The following is a description of a gene set: Human Gene Set: MIR6764_5P Genes predicted to be targets of miRBase v22 microRNA hsa-miR-6764-5p in miRDB v6.0 with MirTarget v4 prediction scores > 80 (high confidence targets). species: Homo sapiens from publication Chen Y, Wang X (PMID 31504780), and this is the list of marker genes: TSPAN17, MLEC, SUSD2, SZT2, SYS1, TNFSF8, KCNJ12, VPS37D, SET, FAM107A, PRRT4, IFITM10, ZFYVE27, ADRA2B, TEAD3, SNPH, PRAG1, SNX33, FBXL18, MIGA2, WNT3A (NCBI Gene Id 89780), PFKFB3, RNF121, BTD, KCNC1, PGPEP1 (NCBI Gene Id 83542), TMEM229B, KCNC2, MIDEAS, ARMC5, SPRING1, RUNX3, TAGLN2, SLC18A1, PBXIP1, NFIC, RAB1B, UCP3, GUF1, VASH1 (vasohibin 1), ATF7IP2, TMEM217, PKP1, LARP1, EFR3B, STC1, ADCY6, GIGYF1, GRM6, PREX2, RBFA, OAZ2, MAVS, SLC8A2, IGFN1, NFASC, CACNG2, TRARG1, VWA3A (von Willebrand factor A domain containing 3A), ECE1, PAQR4, CHTF8, SLC7A8, TRIM67, NPLOC4, ZNF471, TEF, PPP2R5D, ADAMTS4, PCDHGA12, PBX2, APRG1, KREMEN1, CNOT9, PRR30 (NCBI Gene Id 339779), C12orf75, HEYL, DEAF1, TMEM184B, ITPK1, PTPN7, MMP24, TFE3, ZNF629, CWC27, PDE1B, PTPA, TMEM250, NEURL1B, OVOL1, LSS, CACFD1, RPH3A, SIAH2, ACTB (actin beta), NHSL1, ANKRD52, OLFML2A, ZBTB4, SRF, TPBGL, LIN28A, PNMA8B, DPYSL3, LIAT1, BAP1, KIF13A, SPRR2F, MDM4, PTPN6, ZNF474 (NCBI Gene Id 133923), KLK5, SLC1A4, FRMD8, RIMS4, TOLLIP (toll interacting protein), OCM (NCBI Gene Id 91268), EXOC3L2, NAV1, SLA, C1RL, NR2E1, RNF216 (ring finger protein 216), CRY2, MAFF, PNLIPRP3, CYP21A2, RGS8, XPNPEP2, GDF5, OR2H1, CPXM2, FAM53A, C10orf105, NKPD1, ZNF609, TGIF2, CD79A, TMEM245, NEURL1, POFUT2, CXXC1, GIGYF2 (NCBI Gene Id 59281), CALCR, ZC3H12A, SPRED3, CA7, SPRYD3, HNF1A, TSKU, ZNF500, PABPC1, SREBF2, ORAI2, RNPEPL1, ARMC7, ZNF426, SYCP2L, YPEL4, CLCC1, MYRF, MICU1, ICOSLG, NDST1, MAPKAPK2, NPTX1, IP6K1, UBTD1, GRK6, ABHD2, ZNF483, MEF2D, KIAA0930, MGAT3, VAMP1, SORCS2, TMEM132B, EXOC4, PTGES2, ALX4, STUM, BZW1 (basic leucine zipper and W2 domains 1), MXI1, YKT6 (NCBI Gene Id 63236), PLEKHG4B, RABEP2, PTCHD1, SDK1, MISP, COPS7A, SUFU, PCDHGC3, SPSB1, WSCD1, ANKRD34C, CORO2B, MAU2, SYNC, NECTIN1, RAB31, NDOR1, ARHGAP32 (NCBI Gene Id 9743), ZBTB2, SYNGAP1, TCF3, ALAD, LZTS1, TMEM120B, CEP250, PAX7, OTUD1, DAGLA, WNT2B, MTCL2, LRSAM1, CDIP1, PRRC2A, TCF12, MAP4, HHIPL2 (HHIP like 2), PRRT1, ISY1, NCLN, TMEM94, MRTFA, SLC24A2, SPIB, PRKCQ, PPIE, XRCC3 (X-ray repair cross complementing 3), RHO, LIF, BACH2, TAB1, PDGFRB (NCBI Gene Id 5159), SYT7